Given this list of marker genes PCDH17, TMEM59L, DGKG (NCBI Gene Id 1608), PHOX2A, PENK, DCLK2, MAF, MGARP, IRX3, SOX1, PARM1, ADGRA2, MT1JP, ISM2, GRIN2B, B4GALNT1, PRLHR, FBLN7, GATM, EPHB3, OTOP3, LRP2, VSIG2, ADARB2, CD34, GPR83, CD70, CCBE1, TRIM67, OTOP2, PLS3, SLC8A3, SPOCK2 (SPARC (osteonectin), cwcv and kazal like domains proteoglycan 2), NPAS4, SFRP1, NR2F2, ZIC4, ZNF365, DLL4, ADRB1, HOXD13, FRMPD4, FZD2, ST3GAL1, CRMP1, SLC6A5, NPAS1, RIPOR1, RBBP7, CLTRN, SORCS3, CLCN5, GDF7, RASGRF1, HBA1, PLPPR4, TENT5C, MFSD4A, FOXA1, CDH11, GREB1L, CTPS2, NKX2-1, GPR137B, ADCY8, EGR3, OXCT2, MYOD1, SCN4B, BCL2, LGR5, HOXD1, MTM1, HMX2, PRKCE, GDA, THBD, SORCS1, FOXD3, SV2B, PCDH8, B4GALNT2, EPAS1, MECOM, CYFIP1, KCNK2, RTN4RL2, CCNA1, NAGS, DMRT1, OAF, INSM2, C1orf122, F2R, HSF4, RGCC, FIGLA, HTR2C, SLC1A2, CNNM1, CACNA1A (calcium voltage-gated channel subunit alpha1 A), TBX1, VASH1, ALKAL1, SLC12A5, FEZF2, PXMP2, SLCO2A1, IRX5, SDC2, LRFN5, RASGRF2, CDX2, AQP5, TMOD2, CNTFR, ALDH1L1, WNT16, IRX1, SLITRK1, RAX, TUBA4A, RAI2, PIP5K1B, FUT4, RIMKLA, FOXL2, TCEA3, GABRA4, DLX2, AMN, ARHGEF7, SHISA2, TPPP3, SMAD6, DBX2, SCD5, FBXO3 (NCBI Gene Id 26273), USH1G, DMRT2, RAPGEF4, GPC4, HOPX, FRMD3, EFNA3, DCC, VAX2, MIR137HG, CD99, CRABP1, ASTN1, ESX1, NKX3-2, IHH (Indian hedgehog signaling molecule), CDX4, EYA2, COLEC12, ST8SIA2, GJD2, HOXC6, ZEB2, ALX3, NGF (NCBI Gene Id 4803), HLX, NIN, BARHL2, EN2 (NCBI Gene Id 8311), EGR4, LETM2, PPP1R13B, LIPG, KCNAB1, FAM163A, ST8SIA4, HS3ST2, TSPAN6, MLLT3, SIX5, SETD7, EFNA1, LRATD1, EDN3, HTR6, SOX14, ARL9, TRADD, ONECUT2, LCORL (ligand dependent nuclear receptor corepressor like), EPHA10, PTF1A, DLX1, WNT6, BRINP2 (NCBI Gene Id 57795), CACNA1D, RNF128, BARHL1, NR4A3, MESP1, WNT3A, MAFB, GSX1, ZNF287, TCEAL1, KCNC2, SSTR1, NPNT, MAB21L1, HHIP, ZNF703, GFRA2, ZIC1, RIMBP3B (RIMS binding protein 3B), KCND3, RTL4, PRAC1, RIPK3, FOXE3, GNA14, PAX5, ERG, SLC6A3, GSC, NPR3, RGS20, HS6ST3, UNC5C, ASCL1, CLEC4G, ANKRD18A, SLC9A3, KCNMA1, GALNT18, TBC1D1, HHEX, MT1B, HEY1, ADAP2, ISL1, VWA3B, NKX2-3, TMEM132E-DT, PTGR3, CYP24A1, YRDC, KCNK13, TBR1, TRPC5, NKX2-8, TRIM9, CMTM2 (CKLF like MARVEL transmembrane domain containing 2), RIMBP3C, OCA2, DGKI, PRMT8, DLC1, CHODL, LONRF3, ANXA2R, GATA4, ASCL2, BMX, ZNF503, APCDD1L, CBX8, DNM1P46, SOX7, HLF, RSPO1, OLFML2B, IL1RAPL2, EFNB1, GRIN2D, RASGRP1, HOXC5, ACSS1, ABCG4, CLIC6, HPSE2, ISL2, REPS2, GNAS, KCNJ6, NPHS2, RASEF, KCNJ2, BATF3 (NCBI Gene Id 55509), SLIT1, CLEC14A, GATA3-AS1, RBP4, KLHDC1, GPR88, SOX21, HOXC4, HSPA6, NTRK2, ADGRL3, DUOXA2, PRDM12, GPM6B, MT1X, TNFRSF11A, ADAMTS15, LRRC8C, KY, LINC01138, TLX1, WNT3, PHYHIPL, IL7, MLNR, NTNG2, RHOB, CRACDL, SOX17, SLC26A4, VAX1, TRHDE, GDNF, NFIC, CBLN4, HOXD12, SPAG6, CSMD1, SLIT2, BARX1, AMMECR1, HOXB1, ROBO3 (roundabout guidance receptor 3), GPAT3, SHISA6, RBP7, XYLT1 (NCBI Gene Id 64131), LOX, GRIA2, OSR1, PTHLH, SLC27A2, DSCAML1, PKP1 (NCBI Gene Id 5317), SPON2, KCNC4, SOX3, CDH23, E2F4, RAB6C, DUOX2, COMP, TTYH1, SIX3, VIPR2, GPC3, HOXB6, MYF6, COL2A1, SLITRK5, BHLHE22, FGF20, NKX3-1, NIBAN1, EGR2, NTN1, GABBR2, FAM89A, ZMYND15, DSC3, CDH7, ANOS1, SUSD4, TBX3, RSPO2, MAPK11 (mitogen-activated protein kinase 11), HTR7, DIO3, TBL1X, SLC6A11, NRK, PTCHD1, OTX1, TBX5, CHRDL2, PIR, PTGER3, COL24A1, NTRK3, FOXD4L4, NEXMIF, DMRT3, ABHD6, SLC6A2, LHX6, RPRML, KCNH3, KCNJ3, FOXF1, AMER2 (NCBI Gene Id 219287), OTP, PABPC1L2A, TUBA4B, FAM43B, SLITRK2, EPS8, ITPKB, WRAP73, TLL1, CFTR, HTRA4, EML5, SEMA6D (NCBI Gene Id 80031), GAS7 (NCBI Gene Id 8522), ILDR2, NAV2 (NCBI Gene Id 89797), FOXA2, SCP2, NDP, NOS1, SLC1A4, ERICH5, DOK6, TMEM26, MAP6, POU4F3, HOXD3, ADCY4, C2CD4A, CACNA1B, HOXC8, ARL5C, NDUFA4L2, HHAT, POU3F1, TP73 (tumor protein p73), ADAMTSL3, MSX1, FBXO39, SIDT1, SIX6, CACNA1E, SLC32A1, FLT3, CACNA1G, TRPC6, PKNOX2 (PBX/knotted 1 homeobox 2), LBX1 (NCBI Gene Id 10660), GADD45G, CDK16, HNF1B, TMEM54, LBH, CGB7, FGF5, MNX1, SDR16C5, AKR7A2, PAX9, GATA3, SHH, PPM1E, NEFM, OPRD1, RNF121, CFAP91 (NCBI Gene Id 89876), ARHGAP6, GJB2, CRTAC1, CORO6, NOXO1 (NCBI Gene Id 124056), THSD1, NPTX1, RASSF5, IER5L, PAX3, TNFRSF9, CHRD, DPP6, BMP3, STMN2, LRRTM1, COL25A1, PAX8, LHX2, BMI1, GRIK1, C1orf115 (chromosome 1 open reading frame 115), DPPA3P1 (NCBI Gene Id 730515), SFRP5, ABCC6, ATF3, CYP2J2, ANKRD19P, FLI1, TOX2, GPR158, WT1-AS, TSC22D3, ALOXE3, TMEM30B, LMX1B, HOXB3, TMEM132E, WNT7A, LAYN, UCP1, SPATA18, ONECUT1, NEUROG3 (NCBI Gene Id 50674), IL17RA, SGPP2, HBA2, LGI3, EPB41L4A, GFRA1, LTK, HPCAL1, HMX3, TRHDE-AS1, TACSTD2, NKX6-1, NRG1, CCDC140, ERBB4, CHST8, LEF1, TMEM163 (transmembrane protein 163), HS3ST3B1, ASCL4, KCNIP4, CD8A, GRID1, TFAP2C, CXCL14, FOXB1, COCH, KCNV1 (potassium voltage-gated channel modifier subfamily V member 1), NTRK1, CRLF1, FLRT2, KCNA1, HS3ST4 (NCBI Gene Id 9951), PTPRT, PDGFRA, CLSTN2, KCNH1, NBPF3, KCNK12, ELF4, SLCO5A1, CDKN2C, NOTCH2NLA (notch 2 N-terminal like A), ZFYVE28, AMOT, PIGV (phosphatidylinositol glycan anchor biosynthesis class V), TSLP, DPF3, SFT2D2, HSPA4L, UPB1, ZNF436-AS1, PYCARD, PDX1, MT1DP, USP3, CDH13, SLC6A1, SRPX2, DGCR6 (NCBI Gene Id 8214), AFF2, IRS4, CALCA, KCNK4, LINC01597, ANKRD20A11P, GNG12, DACH2, IGSF21, GHR, ECEL1, UCN, MGLL, KLF4, PTGFR, GBX2, GSTM3, FAM24B, TRPA1, ZFHX3 (NCBI Gene Id 463), CA3, SLC35F3, COL4A6, LAMA3, WNT10A, FAM81A, ADAMTS5, ANXA2R-AS1, EMX2, SERTM1, BARX2, FOXG1, GRK3, COL4A5, VDR, SLC24A4, LYSMD2, GIPC2, HOXC11, SLC10A4, CDK5R2, WNT11, PHOX2B, FOXD4L1, GUCY1A1, FBN1, MAPK4, LPL, SYT12, ICAM5, PTGDR, CFAP276, HOXC9, PAPPA, DRD5, KLHL35, OLIG2, HOXB13, LHX8, HTR1A, GPC5, GPR50, NFIA, CEMIP, PGM5, MT1H, SECTM1, GPR12 (NCBI Gene Id 283535), EGFLAM (NCBI Gene Id 133584), SLFN11, PLXNA2, CADM3, CRHR1, CYP26B1, PCSK9, MT1A, NRP1, PAX6, SYT6, ANKRD20A3P, SCNN1G, NHS (NHS actin remodeling regulator), PRICKLE1, PDE4DIP, HES2, EOMES, DLX4, ST8SIA1, EPB41L4A-DT, ZCCHC12, HOXB8, SMIM14, GFI1, NDRG1, CITED1, BHMT, ST3GAL6, SLC66A1, DPY19L2P2, CELF3, MT1M, ITPKA, ENSG00000255537, HOXD8, PROK2, MAL, RYR3, EIF4E3, NKX2-2, PTH2, ADCYAP1, COLGALT2, SCARF2, ASIC2, CDH6, SIAH3, ABTB2, SIM2, ACADL, ANKRD20A2P, CASZ1, PAX2, CXCL16, GUCY1A2, RAB31, HOXD4, PTGER4, FOXO4, KCNA5, SIX2, IRX2-DT, HES7, RAB40B, GPR101, KCNJ5, ANKRD11, INSRR, RGS10, TBX22 (NCBI Gene Id 50945), TBX21, HOXB2, FFAR4, PARD3, ELAPOR1, NGFR, SOX9, BRINP3, TAL1, DKK2, SLC40A1, GATA5, OSR2, UNC5B (NCBI Gene Id 23663), ZBTB16, GUCY2D, COL9A2, C11orf87, NGB, ANKRD27, MAPK8IP2, IGFBP5 (insulin like growth factor binding protein 5), HCN4 (hyperpolarization activated cyclic nucleotide gated potassium channel 4), ALX4, CTNND2 (catenin delta 2), ALX1 (ALX homeobox 1), SLITRK3, TCEAL6, IGF2, RPS6KA6, GSC2, GHSR, NOTCH2, GSX2, NEFH (neurofilament heavy chain), MAP7D2, CIDEA, DUOX1, ATOH8, CWH43 (NCBI Gene Id 92961), ALOX5, SPON1, ADM, SYT10, HOXC13, RARRES1, CNRIP1, NEUROD1, LYPD1, PAQR5, HS6ST1P1, EPHA5, CBR3, KAZALD1, SHOX2, WT1, ASTN2, LRRC3B, CH25H, TCEAL2, TLL2, INA, MCOLN3, ZAR1, FEZ1, DDAH1, FGF13 (NCBI Gene Id 730528), SLC46A2, SLC30A3, PDZD2, ESPN (NCBI Gene Id 83715), ELAVL3, PTGER2, NDNF, MT1P3, BMP8A, CYP1B1, CYP26C1, PIGZ, PITX2, DACH1, ANKRD20A8P, FGF3, TMEM164, CRYBA2, NKD1, PAX7, COL27A1, ITGA11, SHISAL2A, PGR, EGFL6, MGAT5B (alpha-1,6-mannosylglycoprotein 6-beta-N-acetylglucosaminyltransferase B), TCEAL3, ANKRD18B, NR0B1, GALR2, RDH10, RIPK4, PTPRU, EPHA4, RORB, WNT10B, SLCO4A1, IGF2-AS, CYP27B1, CHRNA3, DUSP4, PITX1, KCNA3, NT5C1A, JUN, POLE, MKX, PCSK1N, TUBA8, ETFA, CA10, ADRB3, ELMOD1, LRRC71, EPHB1, POU3F4, PAX1, NEUROG2, RXRG, ALOX15, TLX2, SATB2-AS1, GATA6, RAB33A, KIRREL3, RIN3, NOL4, SLC9A2, PDE8B, EBF3, VSX1, ICAM4, MID1 (midline 1), SPTB, SCTR, CFAP299, GRIN3A, FBXL8, NEFL, PITX3, TMSB15B, AJUBA, DPY19L2, LHX5, WLS, ZNF436, IRX4, METRNL, NPAS2, MAPT, DPYSL5, PLEC, HPCAL4, NEUROD2, SEMA4F, STK32B, FOXD4L3 (forkhead box D4 like 3), SSTR2, TFAP2E, DNAJC22, IMPDH1, HAP1, NBPF11, SIX1, POU4F1, LTBP2, SPOCK3, CACNB4, VSX2, HOXD9, IKZF3, KL, CEBPD, ESAM, NELL1, PCDH11X, NFIX, CD38, RAB9B, SLC30A10, GDF6, COMMD3, DUSP6 (NCBI Gene Id 1848), SQOR, ADAM12, TMEM255A, TBX2, IL15RA, OTX2, ADAMTS18, NPY1R, DKK1 (NCBI Gene Id 22943), BTG2, SRD5A2, APBB1IP, DLX3, TAFA4, GGN, DUOXA1, MAB21L2, NEUROG1, RASL10A, PCDH11Y, FBP1, FBN2, NKX6-2, DHH, ADRA1A, PODN, CYP4X1, IL1RAPL1, TACR1, RIMBP3, ESYT3, RFTN1, ARHGAP20, POMC, GPR27, BNC1, RCSD1, ADGRB2, CDC20B, QRFPR, ADRA2A, ZMYND11, CUZD1, PLPPR1, LRCH2, TMEM88, CSF1, DCHS2, BHLHE23, OPRK1 (NCBI Gene Id 4986), MSC, CRIP1, PYY, HOXD11, LGALS3, NBL1, SLC6A20, SLC5A5, CBLN1, MYO5B, SHC4, OTOP1, ANKRD20A5P, CXCL1 (NCBI Gene Id 2919), ABCC8, PHLDB1, HAND2, MEGF11, KCNQ3, NPY5R, HOXB7, NRCAM, TRIM36, WNT2, PLCB1, NOG, FZD10, GAD2, SLITRK4, BHLHE41, LINC02875, GRIK3, SHOX, FOXJ1, HOXC12, KCTD3 (NCBI Gene Id 51133), FGF9 (NCBI Gene Id 2254), DNER, CD44, NCAM1, SLC18A3, FOXE1, CAMK2N1, INSM1, EVA1C, PRKG1, TNFRSF1B (TNF receptor superfamily member 1B), SLC30A4, ATOH1, KLF14, FEV, CSMD3, FOXL1, OVOL1, FRMPD1, GRM7, CYP26A1, LHX4, NID2, HTRA1, PMP22, SYTL4, ITGA4, GIMAP5, CGB8, ACAN, GABRA2, LAMP5, FOXD2, EMX1, OLIG1, SLC30A2, ANKRD20A1, POU4F2, GATA2, SNX7, SOX10 (NCBI Gene Id 8223), TET2, CRHBP, RGS9BP, HRK, ZNF711, EN1, WNT1, PRKCH, TRH, STXBP6, NRG2, CAV2, TMEFF2, here is a description of the gene set: Human Gene Set: BENPORATH_SUZ12_TARGETS Cancer cells possess traits reminiscent of those ascribed to normal stem cells. It is unclear, however, whether these phenotypic similarities reflect the activity of common molecular pathways. Here, we analyze the enrichment patterns of gene sets associated with embryonic stem (ES) cell identity in the expression profiles of various human tumor types. We find that histologically poorly differentiated tumors show preferential overexpression of genes normally enriched in ES cells, combined with preferential repression of Polycomb-regulated genes. Moreover, activation targets of Nanog, Oct4, Sox2 and c-Myc are more frequently overexpressed in poorly differentiated tumors than in well-differentiated tumors. In breast cancers, this ES-like signature is associated with high-grade estrogen receptor (ER)-negative tumors, often of the basal-like subtype, and with poor clinical outcome. The ES signature is also present in poorly differentiated glioblastomas and bladder carcinomas. We identify a subset of ES cell-associated transcription regulators that are highly expressed in poorly differentiated tumors. Our results reveal a previously unknown link between genes associated with ES cell identity and the histopathological traits of tumors and support the possibility that these genes contribute to stem cell-like phenotypes shown by many tumors. from publication Ben-Porath I, Thomson MW, Carey VJ, Ge R, Bell GW, Regev A, Weinberg RA (PMID 18443585) studied in species Homo sapiens Set 'Suz12 targets': genes identified by ChIP on chip as targets of the Polycomb protein SUZ12 in human embryonic stem cells.